Given this list of marker genes DR1, DYRK1A, SOCS5, TRIB1, ADAMTS10, FZD4, HAPSTR1, GARRE1, RAP1B, SEMA3G, EED, PANK3, LRRC4, TSC22D1, DCBLD2, LRRN3, DAG1, FLRT3, RAP2C, ROBO2, FGA, RIN2, XKR6, PURG, PIK3C2B (NCBI Gene Id 5287), TOGARAM1, UBE2D1, BICD2, STIM2, PAPOLG, COL10A1, SMARCD1, STC1, FAM222A, C1orf52, NEUROD1, UBE2D2, SH2B3, CACNB2 (calcium voltage-gated channel auxiliary subunit beta 2), CCNJ, MTMR2, APP, RRM1, DLG5, GREB1L, NACA (nascent polypeptide associated complex subunit alpha), ADAMTSL3, EMP1, MLEC, GNB1, SRSF5, KMT2A, MBNL1, RAPH1, DDX3Y, HOXD4, ZBTB41, SLC1A1, ANKRD11, JDP2, SELENOI, ASAP1, ASIC1, PIP5K1C, ZNF532, TAL1, ERP44, GZF1, CDYL, ETV5, PLXNB1, PIEZO1, SPOP, REV3L, GJA1, PHLDA1, HAS2, CBFA2T2, SOX11, LRRN1, CMIP, RANBP9, TSHZ3, SPRED1, OTUD4 (NCBI Gene Id 95936), ZNF385B, HNRNPF, RBBP7, MXD1, DDX3X, ADCY6, CCDC18, CBL, TGFBR1, CTTNBP2, POGZ, GPR85 (G protein-coupled receptor 85), FBN2, ANKZF1, GSE1, ZNF207, SGPL1, MPPE1, PRKAA1, MAK (NCBI Gene Id 4117), SOCS2, PHF20L1, DESI2, ZFHX4 (zinc finger homeobox 4), TLK2, AP3S1, EZH2, G3BP2, ABCC5, BTBD3, TMEM161B, RAB1A, TULP4, PURB, SETD2, CPEB2, BICRA, DIPK2A, CDH11, USP47, BCL2L11, ANKRD17, LMNB1, CAV3, ASPN, EYA1 (EYA transcriptional coactivator and phosphatase 1), PTCH1, NUDT11, ERBIN, EMSY, DIP2B, MEPCE, RXRB, KHDRBS3, CTCF, MAGI2, N4BP1, CILK1, PLCG1, DCUN1D3, MARK1, SUB1, CDK5R1, RNF38, USP6, JUNB, MORN4, TEAD3, KBTBD8, ATOSA, UBE2Q1, QKI, SLC39A10, PRP4K, TMED5, NEGR1, KIF1A, FZD6, PDE4A, FAM78A, MOB4, NOVA1, DDIT4, EDEM3, TMEM135 (NCBI Gene Id 65084), SLC30A7, UBE2A, ZNF746, ARFGEF3, UBR7, THRB, EPB41L1, LRRFIP2, OGT, TMEFF1, FOS, RGS1, NLK (nemo like kinase), KCNH7, CDK6, MMP15, MYRIP, MYCN, PCDH8, SOX9, PDE4D, STK4, CAMTA1, DUSP1, ESCO1, PUM2, USP38, KPNB1 (karyopherin subunit beta 1), UNC79, WSB1, NRK, SMARCA1, ING3, GLRA2, SRPK2, FLRT2, CPEB3, PRKCE, FEM1C (fem-1 homolog C), TP63, PTGS2, PPFIA4, DNMT3A, ZCCHC2, CLCN3, CADM1, RASD2, BAZ2A, ABHD17B, DOT1L, DSTYK (NCBI Gene Id 353293), ZFAND3, KAT7, TNRC6B, ARID1A, LONRF1, IGFBP5, RAB5A, ATRX, AEBP2, CDH5, CEBPA, CERS2, SIX4, SEL1L, ZNF24, MAGI1, EXOC5, POMGNT1, BCL9, FBXW11 (F-box and WD repeat domain containing 11), STAG2, ATXN1, PACRG, UBE2D3, NDFIP1, PPFIA1, TERF2, BZW2, ABLIM3, MRGBP, SLC19A2, SH3PXD2A, SYNGAP1 (NCBI Gene Id 8831), FBXW7, here is a description of the gene set: Genes having at least one occurence of the motif GTACTGT in their 3' untranslated region. The motif represents putative target (that is, seed match) of human mature miRNA hsa-miR-101 (v7.1 miRBase). species: Homo sapiens Human Gene Set: GTACTGT_MIR101